Given this list of marker genes PIM3, JAGN1, NDUFAF2, KLF7, FKBP1B, UCP2, ADRA2A, ENY2, PDE8B, here is a description of the gene set: Any process that decreases the frequency, rate or extent of the regulated release of insulin that contributes to the response of a cell to glucose. Human Gene Set: GOBP_NEGATIVE_REGULATION_OF_INSULIN_SECRETION_INVOLVED_IN_CELLULAR_RESPONSE_TO_GLUCOSE_STIMULUS species: Homo sapiens